Given this list of marker genes Akr1c14, Srd5a1, Hsd17b2, Hsd3b2, Hsd3b3, Hsd3b1, Wnt4, Cyp17a1, Srd5a2, Med1, Hsd17b3 (NCBI Gene Id 15487), Scarb1, Hsd3b6, here is a description of the gene set: The chemical reactions and pathways resulting in the formation of androgens, C19 steroid hormones that can stimulate the development of male sexual characteristics. Mouse Gene Set: GOBP_ANDROGEN_BIOSYNTHETIC_PROCESS studied in species Mus musculus